The following is a description of a gene set: Human Gene Set: GOBP_REGULATION_OF_ANTIGEN_PROCESSING_AND_PRESENTATION_OF_PEPTIDE_ANTIGEN Any process that modulates the frequency, rate, or extent of antigen processing and presentation of peptide antigen. studied in species Homo sapiens, and this is the list of marker genes: TAPBPL, HLA-DOB, TREM2, HLA-DOA, HFE, PYCARD